The following is a description of a gene set: from publication Brown AL, Wilkinson CR, Waterman SR, Kok CH, Salerno DG, Diakiw SM, Reynolds B, Scott HS, Tsykin A, Glonek GF, Goodall GJ, Solomon PJ, Gonda TJ, D'Andrea RJ (PMID 16769770) Mechanisms controlling the balance between proliferation and self-renewal versus growth suppression and differentiation during normal and leukemic myelopoiesis are not understood. We have used the bi-potent FDB1 myeloid cell line model, which is responsive to myelopoietic cytokines and activated mutants of the granulocyte macrophage-colony stimulating factor (GM-CSF) receptor, having differential signaling and leukemogenic activity. This model is suited to large-scale gene-profiling, and we have used a factorial time-course design to generate a substantial and powerful data set. Linear modeling was used to identify gene-expression changes associated with continued proliferation, differentiation, or leukemic receptor signaling. We focused on the changing transcription factor profile, defined a set of novel genes with potential to regulate myeloid growth and differentiation, and demonstrated that the FDB1 cell line model is responsive to forced expression of oncogenes identified in this study. We also identified gene-expression changes associated specifically with the leukemic GM-CSF receptor mutant, V449E. Signaling from this receptor mutant down-regulates CCAAT/enhancer-binding protein alpha (C/EBPalpha) target genes and generates changes characteristic of a specific acute myeloid leukemia signature, defined previously by gene-expression profiling and associated with C/EBPalpha mutations. Human Gene Set: BROWN_MYELOID_CELL_DEVELOPMENT_UP Genes defining differentiation potential of the bipotential myeloid cell line FDB. studied in species Mus musculus, and this is the list of marker genes: ARHGEF3, TIFAB, CCL23, GYG1, GP5, CD80, DEGS1, HEXB, CCR2, PIK3CB, MAPK3, PLGRKT, SLC31A2, CPNE3, DOP1B, MCEMP1, TNFRSF1A, NFAM1, GNS, BOLL, ITGAM, ANPEP (alanyl aminopeptidase, membrane), SOAT1, CAP1, TRPM2, FGR, S100A6, SIGLEC12, SAT1, FHAD1, F10, LILRA4, CSF2RA, ACKR1, LASP1, KLHDC4, NQO1, ABCD2, PGD, ANTXR2, CCND2, HLX, CCDC125, DGAT2 (diacylglycerol O-acyltransferase 2), IQGAP1, CTSS, TP53INP1, RNASE4, STOM, PLA2G2E, RACK1, FCGR2A, JUNB, AOAH, C2, ID2, IL1B, MXD1, TCL1A, DSTN, SPACA7, CSTA, TGFBI, CCR1, CLDN1 (claudin 1), RPL13, NXPE4, EDIL3, LYZL2 (lysozyme like 2), ITGAX, EDAR, SERPINC1, CEBPD, S100A11, CNN2, TNNT3, UPP1, VSIR, IL1RN, FCGR1A (Fc gamma receptor Ia), TECPR1, OLR1, HEBP1, ANXA4, IL1R2, MCL1, SLFN12, RPE (NCBI Gene Id 96188), IL4I1, LALBA, CNDP2, G6PD, MPEG1, PLG, CAPG, CAMP, CAPN3, CPD, GSN, CD44, PYGL, MSRB1, GLIPR2, TLR2, APOL1, ALCAM, SIRPA, C5AR1, DAB2, CEACAM1, ESYT2, GRINA, BBLN, WFDC21P, HCK (NCBI Gene Id 3055), REN, RPS17, PLAUR, NPC1, ATP6V1B2, ATP6V1E1, GLRX, QSOX1, EMCN, CLEC6A, PLK3, SCARB2, XDH, SLC6A6, CLEC5A, SEPTIN5, NOS1, LCN2, CD33, SLC30A6, GSTM5, ANXA5, ACTN1, C3, FPR1, FPR2, EREG, GRN, NEAT1, SGMS2, TNF, PSTPIP2, SLC15A3, EGR1, CLEC4A, ZYX, TREM2, CD68 (CD68 molecule), MMP8, ABHD5, CEACAM21, SP100, PZP, TYROBP, BCL2A1 (BCL2 related protein A1), TEX101, CD52, CLEC4C, MYO1B, CYBB, ITGB2